Given this list of marker genes FBLN1, CHM, XYLT1, FBLN5, CLEC3B, CCM2, AGXT (NCBI Gene Id 51432), EFEMP1, CFH, MAPKAPK3, C1QTNF5, APOE, HLA-A, ABCC6 (ATP binding cassette subfamily C member 6), GNAQ, KRIT1, CFHR1, CLCN2, XYLT2, CFI, HMCN1, CFHR3, TIMP3, FBN2 (fibrillin 2), ENPP1, PRPH2, PDCD10 (programmed cell death 10), PIK3CA, here is a description of the gene set: Human Gene Set: HP_ABNORMAL_MORPHOLOGY_OF_THE_CHOROIDAL_VASCULATURE Abnormal morphology of the choroidal vasculature studied in species Homo sapiens